The following is a description of a gene set: Genes up-regulated in comparison of dendritic cells (DC) versus DCs exposed to B. malayi (5 worms/well). studied in species Homo sapiens Human Gene Set: GSE360_CTRL_VS_B_MALAYI_LOW_DOSE_DC_UP Monocyte-derived dendritic cells (DC) and macrophages (MΦ) generated in vitro from the same individual blood donors were exposed to five different pathogens, and gene expression profiles were assessed by microarray analysis. Responses to Mycobacterium tuberculosis and to phylogenetically distinct protozoan (Leishmania major, L. donovani, Toxoplasma gondii) and helminth (Brugia malayi) parasites were examined, each of which produces chronic infections in humans yet vary considerably in the nature of the immune responses they trigger. from publication Chaussabel D, Semnani RT, McDowell MA, Sacks D, Sher A, Nutman TB (PMID 12663451), and this is the list of marker genes: OVOL2, DNAH7, TNFSF14, RPL7, FERMT2, FANCL, CDKN1B, APOBEC2, ZG16, ZNF7, BASP1, SEMA3E, SKP2, RAB14 (NCBI Gene Id 51730), AKAP6, STS, ARIH1, ETV6, DUSP4, HRC, IFIT5, AMELY, TMED2, PLCH1, WIPI2, DDX17, ASTN1, PGM1, GBE1, RPS27A, TSPAN1, RPL21, RNASE1, MKLN1, KBTBD2, APBA3, KRT17, IFNA5, RHOC (ras homolog family member C), BAIAP2 (NCBI Gene Id 10458), ZRSR2P1, MAGEC1, BIRC5, AP4S1, ANXA2P1, VPS11, HNRNPH1, SNW1 (NCBI Gene Id 22938), STIM1 (stromal interaction molecule 1), PEG10, PPP2CA, ZFC3H1 (NCBI Gene Id 26055), ALDH1B1, ZNF75D, COX10, OCM2, IDH3B, MAP4K2, KCNIP4, CHST15, CD38, MYOZ2, SEC13, DNM3, ZCCHC24, CD28, LRP3, SORCS3, C1D, PDE2A, RARB, FAM8A1, SH3BP5, NFIA, CACNA1E, ZFP36L1, PON2, SLC2A3, CTSZ, ASB9, PGAM1, ZNF460, TBC1D4, VDAC3, MPZL2, CETN3, NCR3, H1-10, MT1X (metallothionein 1X, NCBI Gene Id 82523), CCDC69, FAM131A, TEC, FAM13C, GSTZ1, CDC42, BPTF, RASSF8, NCAM2, EIF3A, IGFBP5, CBX7, CRELD1, MYEF2, CRTAM, EXO1, KRT16, CASP5, CELF2 (NCBI Gene Id 10659), MAPK9, P4HA1, KLHL23, SPTBN1, THUMPD1, DOK1, GHRH, RUNDC3A, RBM10, TNC, AVL9, WNT2B, KLRB1 (NCBI Gene Id 3820), CARD8, CFH, ZSWIM8 (zinc finger SWIM-type containing 8), REN (renin), KTN1, ZMYM2, RUNX1T1 (RUNX1 partner transcriptional co-repressor 1), UBXN8, ACTA2, PFKFB1, CTSB, TLR3, TMED3, SULT2A1, TRIM14 (NCBI Gene Id 9830), AKR7A2, TMF1, LILRA2, ZSCAN9, PHF8, BAAT, ITGB5, S100A10, SUMO4, LINC01587, MFAP1, PLCH2, BLM, SDCBP, KDM4B, MAPKBP1, PPY, RPS24, CAND1, EEA1, CETN2, RBM6, SERTAD2, RAD51B, TARBP2, ZRSR2, TAF6 (NCBI Gene Id 6878), SV2A, RRM2, TESK2, CBX1, AKR1B10, DKK1 (dickkopf WNT signaling pathway inhibitor 1), PDYN, CD2AP, SLC29A1, MISP, INPP5J, DLGAP4, PDGFRL, CYB5R1, PPBPP2, CALB2, TNFRSF10B, MCL1, ZC3H4, CLK1, SULT1B1, NCOA6, ZNF177, SGCG, CDKN3, RBPJ, MYRIP, GNLY, TUBG1, MYOF, MMP16, HNRNPA3, RFC1, SLC5A3